Given this list of marker genes GATA2 (GATA binding protein 2), PRF1, SRP72, SH2D1A, TERC, ELANE, FANCB, CLPB, NOP10, TINF2, PALB2, EFL1, XIAP, SBDS, GFI1, RECQL4, ANAPC1, CD27, THPO, HOXA11, NHP2, ACD, TERT, TCIRG1, DNAJC21, IFNG, SRP19, NBN, here is a description of the gene set: Human Gene Set: HP_APLASTIC_ANEMIA Aplastic anemia species: Homo sapiens Aplastic anemia is defined as pancytopenia with a hypocellular marrow.